The following is a description of a gene set: species: Homo sapiens Human Gene Set: GOMF_N_ACETYLTRANSFERASE_ACTIVITY Catalysis of the transfer of an acetyl group to a nitrogen atom on the acceptor molecule., and this is the list of marker genes: SMARCE1, BLOC1S1, NCOA3, NAA50, TAF1, GNPNAT1, NAT8B, SAT2 (spermidine/spermine N1-acetyltransferase family member 2), NCOA1, AANAT, KAT8 (lysine acetyltransferase 8), ARRB1, KAT5, SRCAP, HAT1, ABHD14B, BRPF3, GTF2B, NAA20, CDY2B, ESCO2, MCM3AP, TMEM68, KAT2B, NAT9, NAT1 (N-acetyltransferase 1), NAA11, SAT1, BAZ1A, CREBBP, NAA60, NAA10, KAT6B, SATL1, NAA30, KAT7, CDY1, JADE1, GTF3C4, CDY1B, TADA2A, CLOCK, ATF2, JADE2, KAT6A, TAF1L, CDY2A, TAF10, KAT14, NAA40, ESCO1, EP300, BRPF1 (bromodomain and PHD finger containing 1), ING4, KAT2A (NCBI Gene Id 2648), NAT8, USP22, MEAF6, NAT2, TAF9, NAGS, PYGO2, NAP1L2, ATAT1, ING3, NAT10, BRCA2, NAA80, BRD1, PHF10, HGSNAT, NAT14, NAT8L